The following is a description of a gene set: species: Mus musculus We report the application of single-molecule-based sequencing technology for high-throughput profiling of histone modifications in mammalian cells. By obtaining over four billion bases of sequence from chromatin immunoprecipitated DNA, we generated genome-wide chromatin-state maps of mouse embryonic stem cells, neural progenitor cells and embryonic fibroblasts. We find that lysine 4 and lysine 27 trimethylation effectively discriminates genes that are expressed, poised for expression, or stably repressed, and therefore reflect cell state and lineage potential. Lysine 36 trimethylation marks primary coding and non-coding transcripts, facilitating gene annotation. Trimethylation of lysine 9 and lysine 20 is detected at satellite, telomeric and active long-terminal repeats, and can spread into proximal unique sequences. Lysine 4 and lysine 9 trimethylation marks imprinting control regions. Finally, we show that chromatin state can be read in an allele-specific manner by using single nucleotide polymorphisms. This study provides a framework for the application of comprehensive chromatin profiling towards characterization of diverse mammalian cell populations. Mouse Gene Set: MIKKELSEN_ES_LCP_WITH_H3K27ME3 from publication Mikkelsen TS, Ku M, Jaffe DB, Issac B, Lieberman E, Giannoukos G, Alvarez P, Brockman W, Kim TK, Koche RP, Lee W, Mendenhall E, O'Donovan A, Presser A, Russ C, Xie X, Meissner A, Wernig M, Jaenisch R, Nusbaum C, Lander ES, Bernstein BE (PMID 17603471) Genes with low-CpG-density promoters bearing H3 trimethylation mark at K27 (H3K27me3) in embryonic stem cells (ES)., and this is the list of marker genes: Pde2a, Saxo4, Car15, Cacna1s, Mrgprg, Mylk2, Il13, Trem2, Myl2, Crybb1, Ppy, Htr3b, Chrm1, Sost, Kcnn1